The following is a description of a gene set: studied in species Mus musculus Mouse Gene Set: GOBP_REGULATION_OF_FAT_CELL_DIFFERENTIATION Any process that modulates the frequency, rate or extent of adipocyte differentiation., and this is the list of marker genes: Tnf, Ccdc85b, Gata2, Ppard, Trio, Cebpb, Stk3, Asxl2, Hes1, Cebpa, Zbtb16, Rora, Gps2, Lrp5, Dusp10, Mir448, Mex3c, Tcf7l2, Vstm2a, Ptprq, Sort1, Trib3, Wwtr1, Rorc, Hnrnpu, Lrp6, Fbn1, Wnt10b, C1ql4, Tph1, Flcn, Noct, Aamdc, Bbs12, Pim1, Fto, Syap1, Sirt6, Smad3, Mmp11, Htr2c, Msx2, Sult1e1, Id4, Taf8, Fndc5, Zfpm2, Carm1, Stk4, Gper1, Dlk2, Alms1, Crebl2, Sox13, Id2, Mapk14, Lep, Mecom, Slc7a10, Wnt5b, Cmklr1, Yap1, Fndc3b, Mtor, Enpp1, Sh3pxd2b, Adipoq, Sirt2, Uchl3, Tgfb1, Zc3h12a, Wnt1, Hdac6, Runx1t1, Mir188, Tlcd3b, Adig, Cds1, Zfp36l2 (zinc finger protein 36, C3H type-like 2), Axin1, Nr1d1, Tfe3, Zbtb7b, Lmo3, Pparg, Ccn4, Snai2, Bmal1, Ddit3, Trpv4, Dact1, Xbp1, Zfp36l1, Ccdc3, Tgfb1i1, Bmp7, Trib2, Atat1, Ptgr3, Axin2, Sirt1, Wnt5a, Ift88 (NCBI Gene Id 21821), Gdf3, Sav1, Six1, Prdm16, Wif1, Tmem64, Napepld, Lrp3, Ankrd26, Vegfa, Nucb2, Mkx, Creb1, Akt1, Insig1, Ffar4, Medag, Klf5, Sod2, Gnb3, Jag1, Rarres2, Trpm4, E2f1, Htr2a, Fermt2, Wnt3a, Ptgs2, Zbtb7c, Lpl, Foxo1, Rreb1, Zfp385a, Lpin1, Sfrp1 (NCBI Gene Id 72362), Metrnl, Wdfy2, Frzb, Sfrp2, Igf1, Dlk1, Alox5, Ncor2, Jdp2, Zfp36, Asxl1, Dkkl1, Bmp2